Given this list of marker genes Gpx7, Notch4, Dkc1, Bap1, Blm, Brca1, Apc, S100a4, Hgf, Nbn, Brca2, Rnf8, Hras, Pten, Ccn6, Wnt1, Stat1, Pik3ca, Mcm4, Mnt, Espl1, Trim62 (tripartite motif-containing 62), Cdc37, Prdx1 (peroxiredoxin 1), Rint1, Smarca4, Myc (NCBI Gene Id 17869), Trp53, Fzr1, Met, Tsg101, Bard1, here is a description of the gene set: species: Mus musculus from publication Motenko H, Neuhauser SB, O'Keefe M, Richardson JE (PMID 26092688) Mouse genes annotated to increased mammary adenocarcinoma incidence (MP:0001883) retrieved from the Mouse Genome Informatics database via MouseMine Mouse Gene Set: MP_INCREASED_MAMMARY_ADENOCARCINOMA_INCIDENCE